Given this list of marker genes Bcl2l11, Becn1, Bad, Akt1, Ppara, Fbln1, here is a description of the gene set: A process in which a symbiont alters or subverts a biological process in its host organism. The host is defined as the larger of the organisms involved in a symbiotic interaction. species: Mus musculus Mouse Gene Set: GOBP_SYMBIONT_MEDIATED_PERTURBATION_OF_HOST_PROCESS